Given this list of marker genes MKKS, ELN, GLRA1, MAP3K7, LMNA, TPM3, PAFAH1B1, ATR, SLX4, SLC18A3, LTBP1, DHCR7, COL2A1, BICD2, SLC6A5, XYLT1, COLEC10, EXOSC3, FZD2 (frizzled class receptor 2), AHDC1, GLI3, ZIC3, NODAL, EBF3, AFF3, GPC3, AGRN, GPHN, COL3A1, COL6A3, FANCE, OCRL, FANCG, CPLX1, ALDH18A1, AKT1, ECEL1, ERCC1, PHLDB1, HACE1, CRIPTO (NCBI Gene Id 6997), RYR1, EIF2AK3, FBLN1, MASP1, PPP2R5D, NSDHL, ROR2, UBA2 (NCBI Gene Id 10054), SMOC1, SEC31A, KANSL1, LYSET, ITGA7, CHRM3, SLC6A9, SMC3, SF3B4, CUL7, CLTCL1, DVL1, KLHL41, ADAMTS2, RNU4ATAC, DISP1, FANCF, KIF22, FOXH1, CDON, CCDC47, SHH, COX8A, COL6A1, VAC14, IL6ST, ERI1, B3GAT3, CEP85L, KDM6A, ZC4H2, RUNX2, MYL2, FBLN5, IARS2, PTCH1, SIX1, FKRP, FANCM, ACTA1, ZMPSTE24, POMT1, APC, PTRH2, RECQL4, SLC5A7, COL6A2, DPYSL5, FLNA, TGIF1, IPO8, RAD51C, SNRPB, MACF1, FHL1, B3GALT6, USP9X, BRIP1, PYCR1, GEMIN4, NFIX, NKX3-2, FIG4, SMC1A, LRP4, HK1, COL13A1, GPC4, COLEC11, AEBP1, SLC12A2, UBE3B, NEB, XRCC2, DLL1, FANCC, HNRNPH1, ZNF469, EXOC6B, PLCH1, NIPBL, BRD4, GNPTAB, ABCC9, FGFR1, DHODH, SOX9, CHAT, COL5A2, ATP7A, UBE2T, COL5A1, LARGE1, TFE3 (transcription factor binding to IGHM enhancer 3), HDAC4, WNT5A, GORAB, TOR1A, PYCR2, LMOD3, EYA1, FUT8, SIX3, DNAJC21, ALG9, LRP1, SLC35A3, RFWD3, TBCD, COL27A1, SMO (smoothened, frizzled class receptor), MYH8, MCTP2, ERCC4, ATP6V0A2, SLC25A1, COL12A1, FANCA, AARS1, SLC26A2, FANCL, PIGL, HOXA11, WNT7A, EIF4A3, FANCD2, THRA, RAD51, FLNB, CTBP1, MYO9A, ATP6V1E1 (NCBI Gene Id 529), CFL2, TELO2, MAD2L2 (mitotic arrest deficient 2 like 2), GJA1, BMP4, FGFRL1, LETM1, GLI2, ADAMTSL2 (NCBI Gene Id 9719), FGF8, SHROOM4, EBP, GLRB, NSD2, CD96, FANCB, IFIH1, PUF60, FLI1, BRCA1, RYR3, POLR3B, DSTYK, TRIM8, ERGIC1, POMT2, RAD21, CLCN3, OSGEP, SIL1, FANCI, HPRT1, ATP6V1A, GSC, GAS1, MAP3K20, MYH3, HSPG2, PORCN, KMT2D, NGLY1, OBSL1, SCYL2, PIEZO2, SYT2, RBM8A, TBX15, SPARC, VAMP1, GMPPB, CHRNG, COL1A1, SLC2A10, C12orf57, HDAC8, NAA10, ATAD1, STAG2, TNNT3, SNAP25, ZIC2, KAT6B, COL25A1, TONSL, CHST3, TPM2, SELENON, GDF5, PALB2, PLOD1, YWHAE, STIL, CCDC8, DVL3, EFEMP2, COL1A2, HACD1, MBTPS2, LONP1, BRCA2, ARNT2, TAF6 (TATA-box binding protein associated factor 6), here is a description of the gene set: Hip dislocation Displacement of the femur from its normal location in the hip joint. studied in species Homo sapiens Human Gene Set: HP_HIP_DISLOCATION